The following is a description of a gene set: A change in morphology and behavior of a macrophage resulting from exposure to a cytokine, chemokine, cellular ligand, or soluble factor, leading to the initiation or perpetuation of an immune response. species: Homo sapiens Human Gene Set: GOBP_MACROPHAGE_ACTIVATION_INVOLVED_IN_IMMUNE_RESPONSE, and this is the list of marker genes: NMI, TNF, PLCG2, GRN, TYROBP, IFI35, TREM2, HAVCR2, IL33, SBNO2, PRKCE, SYK, CX3CR1, TREX1, DYSF, LBP, SUCNR1 (NCBI Gene Id 56670), HMGB1, IFNG, TICAM1